Given this list of marker genes Ppargc1a, Ppara, Rptor, Adra1b, Ppp1ca, Git1, Ppp1r3c, Slc4a1, Ppp2ca (NCBI Gene Id 97777), Fbp1, Scarb2, Trp53, Ppp1r3d, Prkag2, Mtor, Myog (myogenin), Ins1, Mtch2, Prxl2c, Sik2, Gpd1, Pfkfb1, Il3, Ppp1r3b (protein phosphatase 1, regulatory subunit 3B), Ppp1r3e, Ins2, Phka1, Mlst8, Gpi1 (glucose-6-phosphate isomerase 1), Insr, Gck, Slc2a6, Prkag3, P2rx7, Tigar, Hif1a, Ep300, Jmjd8, Hsd11b1, Zbtb7a, Hmgb1, Prkaa1, App, Prkag1, Adcy10, Htr2a, Trim63, Trex1, Phkb, Igf1, Mlx, Arl2, Eif6, Prkaca, Uchl1, Kat2b, Phkg2, Psen1, Slc25a12, Ogt, Ncor1, Phkg1, Nupr1, Prkaa2, Flcn, Ppp1cb, Actn3, Stat3, Ifng, Zbtb20, Sirt6, Myc, Arnt, Aldob, Gapdhs, Src (Rous sarcoma oncogene), Slc4a4, Mlxipl, Ddit4, Hdac4, Ier3, Cbfa2t3, Esrrb, here is a description of the gene set: studied in species Mus musculus Any process that modulates the frequency, rate, or extent of the chemical reactions and pathways resulting in the breakdown of carbohydrates. Mouse Gene Set: GOBP_REGULATION_OF_CARBOHYDRATE_CATABOLIC_PROCESS